Given this list of marker genes GOLM2, GABRG2 (NCBI Gene Id 2566), GZMA, UMPS, DPAGT1, AKAP9, CHST6, LGALS1, SPTAN1, SLC35E2B, RPS6KB1, TUBE1, NUP214, PKP2, CAVIN2, NDUFB5, DNTTIP2, ASCC3, PPP2R5C, OPA1, HECW1, NDUFS3, BCCIP (NCBI Gene Id 56647), CFHR2, THBS2, NDUFC1, TDP1, LARP4, POLR3K, PSMA5, TIAM2, NDUFS4, LRP6, FAAP100, PDE6D, ATE1, TERT, TMEM107, ANXA4, PTGER3, PPFIBP1, GALE, DUSP18, PNPO, UROS, STC1, MTSS1, NRROS, FRMD4B, SNX7, PSMD14, HOOK2 (NCBI Gene Id 29911), R3HCC1, ZC3H14 (zinc finger CCCH-type containing 14), ATP5F1B, TOMM40L, HPF1, ZNF703, UBE2A, TAP2, NUP62, ITFG1, CADM3, SPATA24 (spermatogenesis associated 24, NCBI Gene Id 202051), ACACA, NAT8L, MTFMT, SHLD2, WDR4, SNRPD3 (small nuclear ribonucleoprotein D3 polypeptide), PSMG2, THAP11, DDC, SLC35B1, POLR1F, PDZD11, TCL1A, CDKN1A, TBC1D4, SMS, SERPINF1, FGFRL1, CNIH4, ZNF14, PRDX2, MID1IP1, FANCL (FA complementation group L), NDUFA11, GLIPR1, STOX2, COL20A1, TMX1, MARF1, PWP1, ENY2, TEX30, EEF1G, SNX5 (NCBI Gene Id 27131), NDUFAF4, DCUN1D5, IPO7, GSC, C15orf39, CNNM3, DUSP5, CELA1, JUND, PLD1, EXOC7, FMR1, SLC22A14, CLEC5A, DDOST (NCBI Gene Id 1650), AGPAT1, ANXA7, HMGCR, MCPH1, SLC30A4, NAAA, PDIA5, ITGA2B, CBR1, ERI1, H2BC5, KCNQ5, RARG, SFMBT1, CMTM7 (CKLF like MARVEL transmembrane domain containing 7), SLC25A4, SPP1, DDIAS, PSAT1, PSPC1, THBD, TMEM198, NOMO1, MFSD13A, SAE1, TMEM158, PECR, IDH3A, BOC, NPHP4, RPS27L, GALNT3, PPP1R14C, KCNH2, PES1, MN1, CNIH1, ZNF205, CDC45, XPO6, FAM110A, ACTR10, NDUFS5, COX20, GCSH, RAD17, HOXA5, SPRED2, MSRB3, UQCRC2, C6orf136, NAA35, EHD1, DLD, PDSS2, NME2, C12orf75, NR3C2, MTPAP, ESS2, GPRASP3, NMT1, CAMKMT, CNBP, NTRK1, TSR1, CDKN1C, FGD6, ARFIP1 (NCBI Gene Id 27236), CCNG1, PARL, KHSRP, ZNF512B, NDUFB10, AFG2A, TKT, GPN1, TTC33, CTNNBIP1, OSTC, PWWP2A, CRTAP, ARSB, SLC8A3, ABCA12, MZB1, ESF1, here is a description of the gene set: Genes down-regulated in Sez-2 cells (T cell lymphoma): untreated versus IL15. In this study we compared the effects of IL-2, IL-15, and IL-21 on the gene expression, activation of cell signaling pathways, and functional properties of cells derived from the CD4+ cutaneous T-cell lymphoma (CTCL). Whereas both IL-2 and IL-15 that signal through receptors that share the common gamma chain and the beta chain modulated the expression of >genes, IL-21 that signals via the receptor also containing gamma chain up-regulated <genes. All three cytokines induced tyrosine phosphorylation of Jak1 and Jak3. However, only IL-2 and IL-15 strongly activated STAT5, PI3K/Akt, and MEK/ERK signaling pathways. In contrast, IL-21 selectively activated STAT3. Whereas all three cytokines protected CTCL cells from apoptosis, only IL-2 and IL-15 promoted their proliferation. The effects of the cytokine stimulation were Jak3- and Jak1-kinase dependent. These findings document the vastly different impact of IL-2 and IL-15 vs. IL-21 on malignant CD4+ T cells. They also suggest two novel therapeutic approaches to CTCL and, possibly, other CD4+ T cell lymphomas: inhibition of the Jak1/Jak3 kinase complex and, given the known strong immunostimulatory properties of IL-21 on CD8+ T, NK, and B cells, application of this cytokine to boost an immune response against malignant CD4+ T cells. Human Gene Set: GSE8685_IL2_ACT_IL2_STARVED_VS_IL15_ACT_IL2_STARVED_CD4_TCELL_DN species: Homo sapiens from publication Marzec M, Halasa K, Kasprzycka M, Wysocka M, Liu X, Tobias JW, Baldwin D, Zhang Q, Odum N, Rook AH, Wasik MA (PMID 18281483)